The following is a description of a gene set: studied in species Homo sapiens Propionyl-CoA catabolism Human Gene Set: REACTOME_PROPIONYL_COA_CATABOLISM, and this is the list of marker genes: MCEE, PCCA, MMAA, MMUT, PCCB